The following is a description of a gene set: Human Gene Set: DESCARTES_FETAL_PANCREAS_DUCTAL_CELLS from publication Cao J, O'Day DR, Pliner HA, Kingsley PD, Deng M, Daza RM, Zager MA, Aldinger KA, Blecher-Gonen R, Zhang F, Spielmann M, Palis J, Doherty D, Steemers FJ, Glass IA, Trapnell C, Shendure J (PMID 33184181) studied in species Homo sapiens The gene expression program underlying the specification of human cell types is of fundamental interest. The study authors generated human cell atlases of gene expression and chromatin accessibility in fetal tissues. For gene expression, the study authors applied three-level combinatorial indexing to >110 samples representing 15 organs, ultimately profiling ~4 million single cells. The study authors leveraged the literature and other atlases to identify and annotate hundreds of cell types and subtypes, both within and across tissues. Our analyses focused on organ-specific specializations of broadly distributed cell types (such as blood, endothelial, and epithelial), sites of fetal erythropoiesis (which notably included the adrenal gland), and integration with mouse developmental atlases (such as conserved specification of blood cells). These data represent a rich resource for the exploration of in vivo human gene expression in diverse tissues and cell types. Marker genes curated from the annotated cluster as represented in the Descartes Human Gene Expression During Development database., and this is the list of marker genes: DEGS2, NEURL3, UGT2B15, MUC20, UPK1B, SELENOV, ATP12A, ANXA9, CFAP221, PRKAR1B-AS2, SCTR, ROCR, PKHD1, S100A14, ELF3, UPK1A, HMGA2-AS1, VEPH1, GREP1, PLD1, TMPRSS3, VTCN1, ATP1B1, FGFR3, GADL1, ANO3, WNK2, PLPP2, CA4, KLHDC7A, CLDN9, DCDC2, LINC01186, SLC22A8, CLCNKB (NCBI Gene Id 1188), EHF, GS1-24F4.2, KCNJ16, LINC02532, OGDHL, ATP1A1, ATP13A4, PPP1R1B, CFTR, A4GNT, GRHL2-DT, PPARGC1A, NRTN, POU5F1, HKDC1, SLC4A4, ACSM3 (acyl-CoA synthetase medium chain family member 3), LCIIAR, FUT6, NUAK2, HABP2, UGT2A3, SLC3A1, LINC00379, CLDN10, ENSG00000227885, RNU6-287P, GFAP, TRPV6, RNA5SP301, CALB1, PTPRU, LYPD6B, FOLR1, LAMA1, ENSG00000272384, MMP7, ANXA13, CALHM3, ANXA4, LINC01659, KCNJ15, PAQR5, SLC34A2, LINC01836, AGR3, PART1, FUT3, SLC17A4, CCDC198, ENSG00000231119 (NCBI Gene Id 101927377), FAM245A, F2RL1, LAD1, C6 (NCBI Gene Id 12274), IFFO2, VGLL1, SDC1 (NCBI Gene Id 6382), ADAMTS16-DT, NECTIN4, NCMAP, BAAT, DEFB1, SALL4, SHANK2, CDX2, FOXA1, KRT4, TMEM72, TMEM229A, RHPN1-AS1, SFRP5, LEFTY1, SPEF1, CAPS, FAM86FP, HOGA1, RHOV, NEURL1-AS1, LINC01152, ADORA1, GMNN, PRSS22, TMEM139, LINC02343, FGFR2, SYT8, MTND3P10 (NCBI Gene Id 100873239), TTYH1, SLC5A9, OLFM4, ADAMTS16, SOWAHB, SCNN1A